Given this list of marker genes ENTPD6, NLRC4, FNBP4, AHNAK2, ADPRHL1, TSC1, PCNA, MARVELD1, LINC00242, TFCP2L1, LHFPL2, SEZ6L, TRPV3, ASB10, CEP350, PKDCC, PTPRS, CDS2, AHNAK, CCDC9B, H2BC11, RUFY1, CD68, NUDT5, SLC25A42, VPS52 (NCBI Gene Id 6293), KRTAP5-8, LRRC3, PPARD, GFI1, TLR1, CCL1, MTMR11, TACR3, CD48, MOB3B, H2AC11, CDC123, MED25, PRF1, NQO2, SLC35E3, RPS18, AOC1, DNM1P35, KDM4B, here is a description of the gene set: Human Gene Set: FIGUEROA_AML_METHYLATION_CLUSTER_1_DN species: Homo sapiens We hypothesized that DNA methylation distributes into specific patterns in cancer cells, which reflect critical biological differences. We therefore examined the methylation profiles of 344 patients with acute myeloid leukemia (AML). Clustering of these patients by methylation data segregated patients into 16 groups. Five of these groups defined new AML subtypes that shared no other known feature. In addition, DNA methylation profiles segregated patients with CEBPA aberrations from other subtypes of leukemia, defined four epigenetically distinct forms of AML with NPM1 mutations, and showed that established AML1-ETO, CBFb-MYH11, and PML-RARA leukemia entities are associated with specific methylation profiles. We report a 15 gene methylation classifier predictive of overall survival in an independent patient cohort (p < 0.001, adjusted for known covariates). from publication Figueroa ME, Lugthart S, Li Y, Erpelinck-Verschueren C, Deng X, Christos PJ, Schifano E, Booth J, van Putten W, Skrabanek L, Campagne F, Mazumdar M, Greally JM, Valk PJ, Löwenberg B, Delwel R, Melnick A (PMID 20060365) Cluster 1 of aberrantly hypomethylated genes in blasts from AML (acute myeloid leukemia) patients.